Given this list of marker genes NCR3, LY9, BTLA, TENT5C, PLPP5, IL10RA, TRAF5, ARHGAP24, CD82, CCR7, LY6E (NCBI Gene Id 7999), NAPSA, CXCR5, ATP2B1, ZNF331, NR4A3, RBKS, BIRC3, FCER2 (NCBI Gene Id 2208), COL19A1, BIN2, CPNE5, PARVB, CD44, EGR1, KLF4, DUSP2, SP140, CD1C, RIN3, SELL, BIN1, ACP5, AHNAK, NR4A2, SLC2A3, MARCHF1, PNOC, LINC00926, DPEP2, GPR65, NR4A1, CTSH, CD83, CCR6, ITGB7, IL27RA, PLEK, HLA-DOB, SPOCK2, TRBC2, GPR183 (G protein-coupled receptor 183), here is a description of the gene set: from publication He P, Lim K, Sun D, Pett JP, Jeng Q, Polanski K, Dong Z, Bolt L, Richardson L, Mamanova L, Dabrowska M, Wilbrey-Clark A, Madissoon E, Tuong ZK, Dann E, Suo C, Goh I, Yoshida M, Nikolić MZ, Janes SM, He X, Barker RA, Teichmann SA, Marioni JC, Meyer KB, Rawlins EL (PMID 36493756) Human Gene Set: HE_LIM_SUN_FETAL_LUNG_C5_CD5_NEG_MATURE_B_CELL CD5- Mature B species: Homo sapiens